The following is a description of a gene set: Angular cheilitis species: Homo sapiens Human Gene Set: HP_ANGULAR_CHEILITIS A type of inflammation of the lips involving one or both of the corners of the mouth., and this is the list of marker genes: KRT16, CAST (calpastatin), TMPRSS6, AMN, KRT6A, KRT17 (NCBI Gene Id 5103), GJB2, SREBF1 (NCBI Gene Id 6720), KRT6B, CUBN, GJB6, ICOSLG, DSC3